The following is a description of a gene set: from publication Blanco-Melo D, Nilsson-Payant BE, Liu WC, Uhl S, Hoagland D, Møller R, Jordan TX, Oishi K, Panis M, Sachs D, Wang TT, Schwartz RE, Lim JK, Albrecht RA, tenOever BR (PMID 32416070) Genes down-regulated in SARS-CoV-2 infection with Ruxolitinib (ACE2 expressing A549 cells, MOI: 2, 24hpi) Analysis of the transcriptional response to SARS-CoV-2 compared with other respiratory viruses, including MERS-CoV, SARS-CoV-1 (SARS), human parainfluenza virus 3 (HPIV3), respiratory syncytial virus (RSV), and IAV. species: Homo sapiens Human Gene Set: BLANCO_MELO_COVID19_SARS_COV_2_INFECTION_A594_ACE2_EXPRESSING_CELLS_RUXOLITINIB_DN, and this is the list of marker genes: DEGS2, AHCY, CYP4F11, TRAPPC6A, CTSV, C5, CRYAB (crystallin alpha B), COL11A1, CLDN2, UCP2, ETFB, KRT4, PSMB3, DDC, SLC51B, SUSD2, SCIN, ALDH1A1 (NCBI Gene Id 96075), SCARA5, TF, AKR1B1, TM4SF20, C12orf57, PDGFRL, PRDX1, PHB1, SERPINI1, GBP1, ALDH4A1, ISOC2, TK1, ANGPT1, G6PD, GCHFR, SPP1, CTSD, PBXIP1, NDUFS7, CES1, OLFML3, FGB, ASB9, KCNAB2, AKR1B10, SERPINH1, PSAP, AMBP, HABP2, ADAM12, RBKS, IFITM2, NDUFA2, APLP2, MSRB1, GATM, ADGRG2, CD38, HHAT, EPHX1, RBP4, RNASEH2A (ribonuclease H2 subunit A), ENPP1, ROMO1, GPX2, RRM2, CFI, CCND3, TSPAN7, INSL4, CYBA, CTSL, FGG, TXN, PI3, PSMB10, RAB5IF (NCBI Gene Id 55969)